Given this list of marker genes SLC38A3, SLC6A9, SLC38A7, SLC6A5, SLC38A1, SLC38A2, SLC38A4, SLC6A15, here is a description of the gene set: Enables the transfer of a solute or solutes from one side of a membrane to the other according to the reaction: neutral L-amino acid(out) + Na+(out) = neutral L-amino acid(in) + Na+(in). Human Gene Set: GOMF_NEUTRAL_L_AMINO_ACID_SODIUM_SYMPORTER_ACTIVITY species: Homo sapiens